Given this list of marker genes Reg1, Cps1, Foxf1, Aldh1a2, Ass1, Smo, Ednrb, Otc (NCBI Gene Id 18416), Foxl1, Hmgcs2, Egfr, Wnt5a, here is a description of the gene set: Mouse Gene Set: GOBP_MIDGUT_DEVELOPMENT The process whose specific outcome is the progression of the midgut over time, from its formation to the mature structure. The midgut is the middle part of the alimentary canal from the stomach, or entrance of the bile duct, to, or including, the large intestine. species: Mus musculus